The following is a description of a gene set: studied in species Homo sapiens Human Gene Set: IGLV5_37_TARGET_GENES from publication Yevshin I, Sharipov R, Kolmykov S, Kondrakhin Y, Kolpakov F (PMID 30445619), and this is the list of marker genes: NDUFS2, EPCIP-AS1, CUEDC1, ADAT2, ZNF775, HECW2-AS1, MIR4425, CPLX1, C1RL, POLR2B, ELMOD1, MYOM3, INHBA, SDCBP2, PROKR1, MEF2C, TNS3, GJA3, OR51F2, ZNF337, ILDR2, ENAM, CNTNAP2, ELAVL2, TFPI2-DT, KCNH1, MAILR, HPCAL4, FA2H, SPTB, FANK1-AS1, BMX, HPN, LTBP4, C1QL4, TBC1D19, PLOD2, HMX1, IL11, MIR193BHG, ERG, RPL5P11, LRIG3, RN7SKP11 (RN7SK pseudogene 11), SEPTIN4-AS1, CASP7, MFAP2, DTX1, LNCTSI, SALL4, ZNF521, MIR4655, TRAJ52, NKX1-1 (NK1 homeobox 1), COG2, ACTG1, TATDN3, OSMR, LINC01438, CCDC159, LINC02846, CHRM1, MYC, MIR4692, ZMIZ1, MIR2681 (NCBI Gene Id 100616110), FAT3, GRK5, LINC01686, HHIP, FGFR1, ARHGEF1, ARL14EPL (NCBI Gene Id 648335), PLXNB2, AGAP3, LINC01283, PAK3, MTF2, TBPL1, CLEC16A, SUCLG1, MMP15, EPHB6, SPA17, GAPDHP70, CERCAM, NEDD4, RNU6-1291P, AGFG1, NRARP (NCBI Gene Id 441478), TYK2, THRB-AS1, NR2F2-AS1, MRPL39, PRCD (photoreceptor disc component), USP3, FBXO27, BMP1, FOXP2, ROR2, TPD52, NIPAL1, NFATC1, ID2, MIR124-3, TENT4A, PDK4-AS1, SEC62, VWA7, ARHGAP20, TXNRD2, FSCN1, MAML3, ALDOA, MRPL3, THRB, CCDC88C, FRMD1, HES5, EPPK1, GRIN1, HECW2, SEMA6A, LRATD1, MDM4, MAP2, AP5B1, LINC02599, RPL6P25, RUNX1, HES6, ADSS1, NPTX1, LINC01213, CYP26A1, ENTREP1, TNNI2, ADCY5, ZNF395, LINC01615, AQP5-AS1, MYEOV, NFKBIA, BAIAP3, PNRC1, SYCE3, MID1IP1, C1orf43, INTS12, SUPV3L1, PTPRM, AGRN, LINC03044, FOXB2, GFAP, AQP5, NEFM, MTBP, BAZ2A, CCDC88C-DT, HOXB5, TMEM240 (transmembrane protein 240), IGF2, LINC00390, POU2F3, WNT5A, BCOR, GSN, PTPN11P3 (NCBI Gene Id 651828), NDUFS7, CTNNA1, CPA4, PLAAT5, SLC12A8, P4HTM, LINC02611, GFI1B, TFDP2, LINC02609, PHOSPHO1, BCR, CHRD, HOXA-AS2, CFDP1, PTPN14, SHANK2, CPHL1P, STARD10, PLEKHG4B, CASKIN2, SKOR1 (SKI family transcriptional corepressor 1), CHCHD4, SRCIN1, HNRNPA1P65, ST8SIA1, RUNDC3A, LIG1, RAET1K, CYP1D1P, NIBAN1, HNMT, RAB11FIP5, ARHGEF17-AS1, FLNC, AQP7, ADAMTS1, FHL1P1, FGF9, COL7A1, HTR5A, RCAN1, CDC42EP3, RCOR2, FRMD3-AS1, PAFAH2, RPS7, SSBP4, FIGNL2-DT, BPIFB4, DNAJC11, YAP1, TFPI2, STXBP6, F2RL1, LINC01363, CCND2, COL9A2, DUSP5-DT, VAX2, DRAIC, PADI1, SBSPON, IKBKG (NCBI Gene Id 8517), LRRC15, LINC00315, RAP1GAP, CYP26B1, CCDC88B, PDZK1, ADAMTS6, LINC03053, HOXA1, NRGN-AS1, LSP1, TGFBI, MIR8078, KRT5, CITED1, LPIN1, DLX6-AS1, HOXC6, ADAMTSL2, AHNAK, NPIPB8, PRICKLE2, LINC02762, FAAHP1, ENSG00000260316, SF3A3, CABP1, CACNA1D, PAX6, ABHD12, TRAF4, DMAP1, LOHAN2, GRHL3-AS1, PTPRH, ZCCHC4, FZD1, CCDC152, LMNA, CDK12, UBL4A, GPNMB, ALKBH2, PAXBP1, PPP2CB, EGFR, GRIN2A, FRMD4B, ENSG00000221125, FAM83F, LMO1, DUSP5, ENSG00000223343, CLASP1, SIAE, MRPL13, TSBP1-AS1, PSMD3, SEC1P, BCL2, MIR155HG (MIR155 host gene), MIR100HG, HIVEP3, CNGA1, ETS1, TRBV30, SMARCD3, STAB1, LINC01579, TLCD3B, CAMK2B, NF1, LINC01776, TCP11, SLC25A51, ENTREP2, TMEM248, SHH, UBASH3B, ZC3H12A, ZBTB10, RHOD, STAU2, KIAA1210, NSG2, APBA2, GRHL3, THADA (NCBI Gene Id 63892), RNU6-1177P (RNA, U6 small nuclear 1177, pseudogene), BCORL1, LHX4, LFNG, ELN, RNU6-821P, CCDC59, SRPK3, LARGE2, AP4E1, EEF1A1P25, SGK3, SLC22A5, CD24, PBX1, SMG6, LINC01460, PTCH1, ASIC4, PIWIL2, COQ10BP2, ZNF175, CDCA7, DLG3, LASTR, RRP15, ZBTB17 (NCBI Gene Id 7709), ARHGEF16, ATP8B3, PLEC, KANSL3, SPRED3, GSTCD, CNTFR, CCDC187, CLEC2D, LINC01389, CRACR2B, CCDC140, RNU4-60P, THPO, BNC1, DKFZP434A062, PALD1, RIPOR3, KLHL4, LINC02798, TP73, RARS1 (NCBI Gene Id 84715), DDX47, CTSB, KCNN3, ABCC12, GLI2, S100A14, STXBP1, SSBP1, RNVU1-30, TBCAP1, RARA, MYO1A, SERPINB9P1, ALG10, NT5DC3, CDCA2, NGEF, TRIM47, HDAC10, HRCT1 (histidine rich carboxyl terminus 1), TBR1 (NCBI Gene Id 94313), CALM1, DENR, FANK1, HOXA7, GPSM1, MIR3681HG, LRRC20, PRECSIT, ABTB3, CCAR2, BAHCC1, JAG1, NRXN2 (neurexin 2), GNG4, OSGIN1, WDR38, ANKRD40, INHBE, EXD3, SMAGP, SKAP1-AS2, NREP (NCBI Gene Id 9315), RAB13, MOV10L1, CDK5RAP3, ADAP2, ROCK1P1, FGFR3, RFFL (ring finger and FYVE like domain containing E3 ubiquitin protein ligase), RHOT1, ENTPD8, GSN-AS1, PWWP2B, CELSR1, FRA10AC1, DMTN, ETV4, SPRED2, SMIM36, LINC00205, LINC01775, NDST1, GRB10, RTN4R, ATP2B3, PEX3, TIMP1, HAGLR, IL6, RYR3, HEMK1, LHFPL5, GATA2, MYOF, ARL8B, FOXA1, GBA1, LINC01701, RUNDC3A-AS1, VENTX (NCBI Gene Id 27287), NUAK1, SLC2A4RG, CIDECP1 (NCBI Gene Id 152302), NUMA1, NTRK3, MYO5B, ENSG00000228157, FLT3, NSG1, KCNH1-IT1, LAT2 (NCBI Gene Id 7462, linker for activation of T cells family member 2), ASB2, IRS1, CHEK2, S100A2, ZNF3, MCF2L, TBL1X, FAM120B, EML1, DGKG, ATF3, TRAPPC3, ATP6V0D2, COL13A1, TLX2, UBE2E2, CFAP144P2, NUDT9, AFDN, KRTAP2-3, PPCDC, SLC45A4, HMX3, TRNP1, LGI2, ZBTB16, RAB7B, PDE5A, HIVEP2, SH3TC1 (NCBI Gene Id 54436), MIR9-3HG, SLIT2, SMAD7, SSC5D, LINC01122, SETD6, DACT3, WSB2, GAS7, CILK1, PPP2R3B, EPHA10, COLEC10, FBXL8, ENSG00000221345, WDR62, ACAP3, FAM131C, FAM204DP, ELAVL3, BNIP1, RNU6-1039P, KRR1, GDNF-AS1, BEGAIN, POLD4, KCNH2, SRRM3, TBL3, ZNF827, SH2D5, ECEL1P2, TMTC2, SAMD1, WNT3A, PRKCSH, GSE1, TBC1D1, VGF, ALDH1A2, KEAP1, KLKP1, GNB2, ATXN2L, NGF, ENC1, EFHD1, TRAJ7, WEE2-AS1, SNORA108, IQCN, OSMR-DT, PRKAB2, NEUROG2-AS1, UBE2E2-DT, NIBAN2, COL16A1, LINC01778, PDHX, USHBP1, DAB2IP, NOTUM, EHD1 (NCBI Gene Id 10938), POT1-AS1, KDM3B, CRPPA-AS1, RNF166, ENSG00000235978, AFAP1, LINC00607, ANKAR, FLT3LG, CFAP74, CYB561, NSL1, PADI4 (NCBI Gene Id 82795), NIM1K, SLC26A4, SLC12A9, ATP2B2, FGF1, CNNM2, TCF7, PDLIM2, MX2, COL9A3, FCSK, TAFA5, TTC6, MIR1249, TNNT1, KIF12, ZNF609, LHX6, CLIP1, ADAM7-AS1, PDCD1, MRPL1, KCNT1, NSA2, ANXA11, TEFM, NOS3, NET1, COL21A1, AFDN-DT, FOXE1, MIR663AHG, HGFAC, RN7SKP192, EXOC3L4, CLEC11A, CXCL12, MCF2L-AS1, NOXA1, FENDRR, PLXNC1, HOTAIRM1, WNT10B, PBX3-DT, PAUPAR (NCBI Gene Id 440034), E2F6 (E2F transcription factor 6), FHL1, IRF4, MID1IP1-AS1, HOXC9, TRIB2, BRINP2, LIMCH1, VPS36 (vacuolar protein sorting 36 homolog), GREM1, CRLF1 (NCBI Gene Id 9244), PKD1L2, MAL-AS1, SYNE2, HMG20A, RHOBTB3, PRKCE, COL23A1, METTL25, CTBP2, ATP11C, MIR6782, NNMT, MBOAT7, ATXN1-AS1, LINC02614, TEX48, RRAGD, MYO18B, STAT1, AHCY, ZNF503-AS1, MOGAT3, GFM2, MN1, AMPD3, PRPH, SEC13